The following is a description of a gene set: species: Homo sapiens Any process that activates or increases the frequency, rate or extent of nuclease activity, the hydrolysis of ester linkages within nucleic acids. Human Gene Set: GOBP_POSITIVE_REGULATION_OF_NUCLEASE_ACTIVITY, and this is the list of marker genes: PCNA, HSPA1A, PRKCD, RPS3, AKT1